The following is a description of a gene set: An thiol-dependent isopeptidase activity that cleaves SUMO from a target protein to which it is conjugated. Human Gene Set: GOMF_DESUMOYLASE_ACTIVITY species: Homo sapiens, and this is the list of marker genes: SENP2, SENP3, SENP1, HINT1 (histidine triad nucleotide binding protein 1), SENP5, USPL1, DESI1